Given this list of marker genes NCK1, RPL26L1 (NCBI Gene Id 51121), RPS12, DHX9, EIF2B3 (NCBI Gene Id 8891), RPS11, RBM24, EIF4G1, RPL27 (NCBI Gene Id 6155), IGF2BP1, RPL10A, RPL35A, RPS26, RPS15, RPS13, RPL7 (NCBI Gene Id 6129), RWDD1, RACK1, RPS24, RPL39, RPL13, RPS3, RPL6, MCTS1, RPS8, CPEB2, RPS7, DENR, RPS23, SLBP, RPL14 (NCBI Gene Id 9045), RPL10, RPL35 (ribosomal protein L35), RPL15, EIF4A2, SARS1, SMYD5, RPS18, RPL24, PIWIL2, EIF2B5, UBA52, FTSJ1, RPL38, DHX36, RPL32, RPS16, RPL7A, RPS27, EIF3B, HNRNPU (heterogeneous nuclear ribonucleoprotein U), RPL23, EIF3J, RPLP0P6, EIF5, RPL36, EEF2, EIF3D, EIF3I, MTOR, PAIP1, EIF2S3B, ETF1, YTHDF2, RPS28, YBX3, RPL13A, EIF3G, RPS9, EIF4H, EIF2S2, RPL41, NCBP2, RPS20, GTPBP1, RPL5, RPL30, DHX29 (NCBI Gene Id 94080), RPL28, EIF3H, YBX1, RPL37, RPL34, RPL36A, CPEB1, SYNCRIP, RPL9, PARP16, PKP1, HHEX, DRG1, RPL31, DRG2, EIF4B, RPL11, EIF3A, UNK, NCBP1, ZCCHC13, RPL37A, RPS19, EIF3F, RPL18 (NCBI Gene Id 6141), RPS17 (NCBI Gene Id 6218), EIF3M, RPS14 (NCBI Gene Id 6208), ALKBH3, RPL18A, CPEB3, PKM, FMR1, RPL4, LIN28A, AARS1, RPL22, METTL3, NEMF, RPLP0, RPS25 (NCBI Gene Id 6230), EIF3C (eukaryotic translation initiation factor 3 subunit C), RPL26, EIF2B1, RPL29, RPS5 (NCBI Gene Id 6193), IMPACT, EIF2D, EIF3L, RPLP2, MIF4GD, RPL12, EIF3K, PABPC1 (poly(A) binding protein cytoplasmic 1), RPL21, ZNF385A, RPS6, EIF4A1, RPS10, RPS4X, ZC3H15, EIF2B4, NMNAT2, RPS15A, RPL8, HNRNPD, RPS21, RBM4 (NCBI Gene Id 5936), SH3BGRL, RPL22L1, RPL3, EIF2B2, EIF3E, RPL27A (ribosomal protein L27a), EIF3CL, EEF1D, CPEB4, EIF2S3, RPS29, CNBP, RPS3A, FAU, RPSA, MCTS2, RPLP1, RPL17, RPL23A, RPSA2, CSDE1, AKT2, RPL19, RPS27A, RPS2, here is a description of the gene set: The chemical reactions and pathways resulting in the formation of a protein in the cytoplasm. This is a ribosome-mediated process in which the information in messenger RNA (mRNA) is used to specify the sequence of amino acids in the protein. studied in species Homo sapiens Human Gene Set: GOBP_CYTOPLASMIC_TRANSLATION